The following is a description of a gene set: Human orthologs of genes down-regulated in the crb ('crash and burn') zebrafish mutant that represents a loss-of-function mutation in BMYB. species: Homo sapiens Human Gene Set: SHEPARD_CRASH_AND_BURN_MUTANT_DN from publication Shepard JL, Amatruda JF, Stern HM, Subramanian A, Finkelstein D, Ziai J, Finley KR, Pfaff KL, Hersey C, Zhou Y, Barut B, Freedman M, Lee C, Spitsbergen J, Neuberg D, Weber G, Golub TR, Glickman JN, Kutok JL, Aster JC, Zon LI (PMID 16150706) A major goal of cancer research has been to identify genes that contribute to cancer formation. The similar pathology between zebrafish and human tumors, as well as the past success of large-scale genetic screens in uncovering human disease genes, makes zebrafish an ideal system in which to find such new genes. Here, we show that a zebrafish forward genetic screen uncovered multiple cell proliferation mutants including one mutant, crash&burn (crb), that represents a loss-of-function mutation in bmyb, a transcriptional regulator and member of a putative proto-oncogene family. crb mutant embryos have defects in mitotic progression and spindle formation, and exhibit genome instability. Regulation of cyclin B levels by bmyb appears to be the mechanism of mitotic accumulation in crb. Carcinogenesis studies reveal increased cancer susceptibility in adult crb heterozygotes. Gene-expression signatures associated with loss of bmyb in zebrafish are also correlated with conserved signatures in human tumor samples, and down-regulation of the B-myb signature genes is associated with retention of p53 function. Our findings show that zebrafish screens can uncover cancer pathways, and demonstrate that loss of function of bmyb is associated with cancer., and this is the list of marker genes: LGMN, CDC27, SHCBP1, OLIG2, MT2A, DEK, PMEL, NDE1, POU3F3, NDUFB3, PRC1, KDM6A, ASCL1, ASPM, LMNB2, SOX21, TNXB (NCBI Gene Id 7148), RLF, ARID5B, ANLN, PON1, G3BP2, NMRK2, GOLGB1 (NCBI Gene Id 2804), SLAIN2, JAG1, PUM1, PLK4, CCNB1, SFRP1, MASTL, NELL2, DBX1, MELK, AP4M1, PHF3, GFAP, BORA, KIF11, GUCA1A, PHF20L1, RASGEF1A, CYRIB, MYH8, OIP5, EN2, GREB1, PPP1R3C, CEP55, GPSM1, SKI, PTPRN, POU3F1, ARHGAP12, KIF23, TPX2, HMGA1, KIF14, CCNB2, DLGAP5, ARMC1, HDAC2, HES6, SLIT3, MYO10, FGFR4, RHO, FBXO5, KNL1, CTSL, MDK, C17orf49, ZNF511, FOXB1, TM7SF2, FZD10, SLX1B, BIRC5, TMEM263, ZNF585A, KCTD17, SOX11 (NCBI Gene Id 6664), ENO3, AKAP9, CEP295, MBD2, NEUROD4, ST8SIA2, KRT2, MKI67, TNRC6C, BUB3, MIB1, CCNB3, GDF10, GTSE1, FUBP1, NEUROG1, CRYBB1, TRIM39, KDM3A, POU3F2, PARPBP, TK1, IFT46, CDC20, HOXB3, FAM76A, NR2F1, BMS1, PPP1R3G, CKAP2, LHX1, FZD5, PCDH18, EBF1, SOX3 (SRY-box transcription factor 3), DDX20, MTUS1, TOX3, PLEKHF1, ADARB2, PLP1, AURKB, ZIC2, NOVA2, RTKN, FAM13B, INKA2, PAX2, HES3, CTDSPL2, DIO2, ZNF184, CDCA2, NUMA1, CDK1, PGBD4 (NCBI Gene Id 161779), DPYSL3, MYCL, PRR11, CHD5, KIF2C, ARNT2, SLC34A1, OTP, RACGAP1, CKS2, PIF1, SMTN, UCP2, SLC44A2, KHDRBS1, PTPRO, PRIM2, ECT2, NFIL3, TUBA8, CDC14B, TTN, HES5, ATP1A1, FOXM1, DDX17, LZTS3, CEP250, HEY1, FZD9, GAS1, PCDHGC3, BUB1B, TTK, TACC3, TMPO (thymopoietin), OTX2, WDR74, ANP32B, PTEN, NOTCH2, SMAD3, NEIL3, IRX1, HMGN3, SYNCRIP, ELAVL4, INSM1, CRYBA4, HLX, ZP2, CDCA3, S1PR1